Given this list of marker genes FDPS, ALDH1A3, GGPS1, LSS (NCBI Gene Id 4047), DHRS9, RDH10, CYP1A1, HMGCS1, HMGCS2, ALDH8A1, PRMT3, RBP1, ALDH1A2, RPE65, AKR1C3, BCO1, here is a description of the gene set: species: Homo sapiens Human Gene Set: GOBP_TERPENOID_BIOSYNTHETIC_PROCESS The chemical reactions and pathways resulting in the formation of terpenoids, any member of a class of compounds characterized by an isoprenoid chemical structure.